Given this list of marker genes Csf1, Nmb, Gsk3b, Tcirg1, Grem1 (gremlin 1, DAN family BMP antagonist), Tnfsf11, Npr3, Flt3l, Junb, Nmbr, Phf7, Ocstamp, Nfix, Pth, here is a description of the gene set: Mouse Gene Set: GOBP_OSTEOCLAST_PROLIFERATION The multiplication or reproduction of osteoclasts, resulting in the expansion of an osteoclast cell population. An osteoclast is a specialized phagocytic cell associated with the absorption and removal of the mineralized matrix of bone tissue, which typically differentiates from monocytes. species: Mus musculus